Given this list of marker genes Fjx1, Srsf11, Rsf1, Tef, Tnfrsf19, Snx18, Setd7, Malat1, Tnpo2, Nrxn3, Dlgap2 (NCBI Gene Id 244310), Mir9-3hg, Pfkp, Pik3r1, Bsn, Smarcc2, Ankrd11, Ttc14, Aopep, Sobp, Pcdh19, Rbm25, Acvr1c, 6430548M08Rik, Lingo1, Chka, Slc4a4, Gna13, Emc10, Cygb, Plxnc1, Csnk1a1, Rpl22, Klf9, Trak1, Spock2, Or51e2, Atn1, Gnai1, Cyria, Cplx2, Wnk1, Slc6a1, Dnm2, Ftx, Cpeb2, Clec16a, Map3k2 (mitogen-activated protein kinase kinase kinase 2), Creg2, Eps15, Ncs1, Mir9-2hg, Aftph, Ncdn, Marcks, Pgm2l1, Zc3h11a, Dlg4, Mirg, Bpnt2, Grk3, Prkcg, Mycbp2, Cnnm1, Ptk2b, Trim2, Ttyh3, Opcml, Prrc2b, Kif5c, Bltp2, Numbl, Ildr2 (NCBI Gene Id 98467), Dleu2, Ehd3, Chd4, Fbxo41, Slc8a1, Arglu1, Olfm1 (NCBI Gene Id 99427), Macroh2a1, Nr2c2, Ralgapa1, Eif3c (NCBI Gene Id 66685), Slc25a23, Camk2a, Ptprk, Src, Dab2ip, Gm32444, Lpgat1, Dgkd, B3gat1, Brd1, Ubqln2 (ubiquilin 2), Ppp1r1b, Ptprj, Sp4, Lin7a, Trim8, Oip5os1, Mapre2, Mink1 (misshapen-like kinase 1 (zebrafish)), Tcaf1, Auts2, Rictor, Asap1, C78859, Zfp445, Leng8, Slc17a7, Nfix, Ppp2r5e, Cdk5r1, Sema6b, Foxp1, Ppp2r2c, Gprin3, Mef2c, Timp2, Pbx1 (NCBI Gene Id 98516), Zeb2, Eid1, Sptbn1, Ntm, Cpne6, Megf9, Far1, Mirlet7b, Nacc2, Zbtb16, Spred1, Cdc40, R3hdm1, Ubr2, Dot1l, Syn2, Smarca5, Gria1, Ogt, Atp2b1, Meg3, Plppr5, Cep70, Atp8a1, Rimbp2, Safb2, Cd99l2, Smg7, Egln1, Lpin2, Usp7, Endod1, Ccni, Gsk3b, Cnr1, Mtdh, Pom121, Samd12, Rhou, Igf1r, Chd9, Ajm1, Acin1, Actn1, Rock1, Mir22hg, Cyfip2, Dnajc27, Slc1a2, Nectin1, Atp1a3, Slc1a3, Srrm1, Pygm (NCBI Gene Id 19309), Mia3, Bin1, Sp3, Tial1, Nptxr, Ubtf, Ttc7b, Klhl24 (NCBI Gene Id 98030), Zfp804a, Prkab2, Lrrc7 (leucine rich repeat containing 7), Myh9, Paqr8, Shoc2, Ddx46, Fndc3a, Rbm39, Ski, Stk4, Ark2c, Tmod2, Sntb2, Tcf4, Spaca6, Cbll1, Mir377, Lsm11, Smarca2, Nfic, Tnrc18, A330023F24Rik, Gprin1, Tmem178b, here is a description of the gene set: from publication Stark KL, Xu B, Bagchi A, Lai WS, Liu H, Hsu R, Wan X, Pavlidis P, Mills AA, Karayiorgou M, Gogos JA (PMID 18469815) Individuals with 22q11.2 microdeletions show behavioral and cognitive deficits and are at high risk of developing schizophrenia. We analyzed an engineered mouse strain carrying a chromosomal deficiency spanning a segment syntenic to the human 22q11.2 locus. We uncovered a previously unknown alteration in the biogenesis of microRNAs (miRNAs) and identified a subset of brain miRNAs affected by the microdeletion. We provide evidence that the abnormal miRNA biogenesis emerges because of haploinsufficiency of the Dgcr8 gene, which encodes an RNA-binding moiety of the 'microprocessor' complex and contributes to the behavioral and neuronal deficits associated with the 22q11.2 microdeletion. studied in species Mus musculus Genes up-regulated in prefrontal cortex (PFC) of mice carrying a hemizygotic microdeletion in the 22q11.2 region. Mouse Gene Set: STARK_PREFRONTAL_CORTEX_22Q11_DELETION_UP